Given this list of marker genes Bglap, Rgn, Lox, Ggcx, Kat2a, Kdr, Bglap2, Gli3, Ghrl, Dspp (NCBI Gene Id 666279), Tmem119, Tapt1, Tnn, here is a description of the gene set: Mouse Gene Set: GOBP_REGULATION_OF_BONE_DEVELOPMENT species: Mus musculus Any process that modulates the frequency, rate or extent of bone development.